The following is a description of a gene set: The properties of transcriptional networks early in the differentiation of human pancreatic cells are inferred from the properties of well-studied networks in mouse models. In mice, the first visible sign of pancreatic development is the appearance of pancreatic buds at about embryonic day 9. The cells in these buds are already committed to differentiate into specialized cells of the exocrine and endocrine pancreas. Expression of transcription factors including Hnf1b, Hnf6, and Pdx1, as well as responsiveness to Fgf10 (fibroblast growth factor 10), up-regulates the expression of factors including Ptf1, Onecut3, Lrh1, and Nkx6.1. part of: Regulation of beta-cell development Reactome Pathway: Regulation of gene expression in early pancreatic precursor cells species: Homo sapiens, and this is the list of marker genes: ONECUT1, PDX1, ONECUT3, NKX6-1, HNF1B, FGF10, PTF1A, NR5A2